Given this list of marker genes FSHB, POMC, NKX2-1, FGFR1, GLI3, CHD7, LHX3, PCSK1, here is a description of the gene set: Gonadotropin deficiency A reduced ability to secrete gonadotropins, which are protein hormones secreted by gonadotrope cells of the anterior pituitary gland, including the hormones follitropin (FSH) and luteinizing hormone (LH). studied in species Homo sapiens Human Gene Set: HP_GONADOTROPIN_DEFICIENCY